Given this list of marker genes MSH3, KIT, APC2, SETBP1, BCL10, NSD1, PRKAR1A, PDE11A, FGFR3, STK11, MNX1, here is a description of the gene set: Teratoma species: Homo sapiens Human Gene Set: HP_TERATOMA The presence of a teratoma.